Given this list of marker genes MEIOB, NDUFB10, ZNF205, TRAF7, LUC7L, TPSG1, MSRB1, RPUSD1, CHTF18, JPT2, SYNGR3, RNF151, PGAP6, UNKL, PKD1, HBZ, RPS2, SSTR5, ELOB, HBA2, MMP25, FLYWCH2, MPG, NME3, MRPS34, RHBDL1 (NCBI Gene Id 9028), TPSB2, MSLNL, NUBP2, PRR35, RGS11, IFT140, WFIKKN1, IL32, GNPTG, PRSS22, METTL26, KREMEN2, HBQ1, THOC6, CRAMP1, HBA1, WDR24, MCRIP2, METRN, EME2, CAPN15, NTHL1, TBL3 (transducin beta like 3), ZNF598, NPW, MRPL28, RAB40C, LMF1, CACNA1H, TNFRSF12A, NHERF2, ARHGDIG, PKMYT1, TSR3, TELO2, BAIAP3, FBXL16, RAB26, PRSS21, PAQR4, HAGHL, SNRNP25, RHBDF1, SRRM2 (NCBI Gene Id 51462), GFER, JMJD8, FAM234A, PIGQ, PTX4, HBM, TPSD1, C1QTNF8, UQCC4 (NCBI Gene Id 283951), PRSS27, TSC2, DECR2, MSLN, NOXO1, ZNF213, CLDN6, POLR3K, PRSS33, KCTD5, RHOT2, PDIA2, HS3ST6, RPL3L, SPSB3, AXIN1, WDR90, HCFC1R1, FLYWCH1, TMEM204, SOX8, TPSAB1, CIAO3, RAB11FIP3, ANTKMT, ZG16B, FAHD1, NME4, CCDC78, STUB1, MAPK8IP3, ZSCAN10, NPRL3, HAGH (hydroxyacylglutathione hydrolase), UBE2I, IGFALS, CLCN7, CLDN9, NHLRC4, GNG13, here is a description of the gene set: Genes within amplicon 16p13 identified in a study of 191 breast tumor samples. species: Homo sapiens from publication Nikolsky Y, Sviridov E, Yao J, Dosymbekov D, Ustyansky V, Kaznacheev V, Dezso Z, Mulvey L, Macconaill LE, Winckler W, Serebryiskaya T, Nikolskaya T, Polyak K (PMID 19010930) Human Gene Set: NIKOLSKY_BREAST_CANCER_16P13_AMPLICON A single cancer cell contains large numbers of genetic alterations that in combination create the malignant phenotype. However, whether amplified and mutated genes form functional and physical interaction networks that could explain the selection for cells with combined alterations is unknown. To investigate this issue, we characterized copy number alterations in 191 breast tumors using dense single nucleotide polymorphism arrays and identified genes with copy number gain organized into 30 amplicons. Amplicons were distributed unequally throughout the genome. Each amplicon had distinct enrichment pattern in pathways, networks, and molecular functions, but genes within individual amplicons did not form coherent functional units. Genes in amplicons included all major tumorigenic pathways and were highly enriched in breast cancer-causative genes. In contrast, genes with somatic mutations in breast cancer were distributed randomly over the genome, did not represent a functionally cohesive gene set, and were relatively less enriched in breast cancer marker genes. Mutated and gained genes did not show statistically significant overlap but were highly synergistic in populating key tumorigenic pathways including transforming growth factor beta, WNT, fibroblast growth factor, and PIP3 signaling. In general, mutated genes were more frequently upstream of gained genes in transcription regulation signaling than vice versa, suggesting that mutated genes are mainly regulators, whereas gained genes are mostly regulated. ESR1 was the major transcription factor regulating amplified but not mutated genes. Our results support the hypothesis that multiple genetic events, including copy number gains and somatic mutations, are necessary for establishing the malignant cell phenotype.